The following is a description of a gene set: Striated Muscle Contraction studied in species Mus musculus Mouse Gene Set: REACTOME_STRIATED_MUSCLE_CONTRACTION, and this is the list of marker genes: Myl4, Tmod2, Myl2, Myl3, Mybpc3, Mybpc1, Actn3, Tcap, Tpm4, Tnni1, Tnnc1, Tnni3 (NCBI Gene Id 21954), Tnnt2, Tmod1 (tropomodulin 1), Actc1, Myh8, Myh6, Mybpc2, Vim, Neb, Tmod3, Actn2, Tpm2, Myh3, Acta1, Tnnt3, Dmd, Myl1, Tpm1, Tnni2, Tmod4, Tnnc2, Des, Tnnt1, Tpm3